The following is a description of a gene set: Human Gene Set: GOBP_REGULATION_OF_BEHAVIOR Any process that modulates the frequency, rate or extent of behavior, the internally coordinated responses (actions or inactions) of whole living organisms (individuals or groups) to internal or external stimuli. species: Homo sapiens, and this is the list of marker genes: PTGDS, PARP1, INS, GHSR, ARRDC3, DRD2, EPHB2, PENK, AIM2, NPSR1, LEPR, ADORA2A, TACR3, GHRH (growth hormone releasing hormone), MBD5, RAG1, INSL5, STRA6, MTOR (NCBI Gene Id 2476), NLGN1, CHRNB2, ZFHX3, RETN, STAT3, EIF2AK4, GHRHR, FXR1, CSF2, HTR2B, MEF2C (NCBI Gene Id 4208), PER3, NPAS2, NMU, KCNA2, NPY, MC3R, SGIP1 (NCBI Gene Id 84251), TTC21B, ADORA1, MTNR1B, HOXA1, MC1R, CCL3, HTR1B, OPRK1, QRFP, HTR1D, VPS35, CRH, UCN, HTR1A, APOE, BAIAP3, NR1D1, GRPR, HCRTR2, SLC24A4, GRIA1, DLG4 (discs large MAGUK scaffold protein 4), GRP, GNB3, NR4A3, CFAP20, CNTNAP4, NAPEPLD, ADRB1, NPS, AHI1, MC4R, GHRL (ghrelin and obestatin prepropeptide), GPR171 (G protein-coupled receptor 171), MDK, RXFP4 (relaxin family peptide/INSL5 receptor 4), HDAC2, RELN, NPY2R, AGRP